Given this list of marker genes Echs1, Hadh, Acadm, Hadha, Hadhb, Mecr, here is a description of the gene set: Beta oxidation of decanoyl-CoA to octanoyl-CoA-CoA Mouse Gene Set: REACTOME_BETA_OXIDATION_OF_DECANOYL_COA_TO_OCTANOYL_COA_COA species: Mus musculus